Given this list of marker genes Iglc2, Cd79a, Fkbp2, Atf6, Vps37a, Prdx4, St6gal1, Impdh1, Tnfaip8, Dusp4, Xbp1, Mzb1, Slamf7, Neat1, Iglc1, Itgal, Edem1, Tspan13, Ly6d, Lman1, Iglv3, Cytip, Mars1, Gramd2b, Tpst2, Prg2, Tmem248, Trp53inp1, Iglv1, Kcnn4, Sla, Serp1, Txndc5, Odc1, Txndc11 (NCBI Gene Id 76370), Gm8818 (NCBI Gene Id 676400), Iglc3 (NCBI Gene Id 70018), Igkc, Atosa, Gimap5, Igha, Cd28, Pon3, Cd69, Tnfrsf17, Tent5c, Ssr4, Zbp1, Evi2a, Eaf2, Edem2, Il2rg, Sec11c, Tmem123, Slc16a6, Tmem176a, Gm5547, 1700017B05Rik, Derl3, Ly6c2, Creld2, Ccr10, Glipr1 (NCBI Gene Id 73690), Jchain, Cacna1s, Cd52, Slpi, Pou2af1, here is a description of the gene set: studied in species Mus musculus Table S2: Representative genes of each cell cluster from publication Zhang L, Long W, Xu W, Chen X, Zhao X, Wu B (PMID 35669188) Mouse Gene Set: ZHANG_UTERUS_C15_B_CELL